Given this list of marker genes CPPED1, PPP1R14B, INPP5E, PPP1R14A, FAN1, PPP1R8, MGAT5, MTMR11, PABIR2, PPP4R3A, SH3RF2, TPTE2, PTPMT1, PLCB4, NANP, VRK3, DUSP8, PPP1R12A, DLG1, DUSP26, PTP4A3, G6PC3, NT5C1A, PTPN20, CDC14B, PPP3CB, ARL1, PLCD3, PDE3A, MYOZ1, CDCA2, RNGTT, DUSP22, PPP1R2C, PPP1R1B, PPP2R2B, PPP2R2C, MTMR3 (myotubularin related protein 3), YWHAE, MYH8, GNA12, PTP4A1, HSP90AB1, PGAM5, ALPL, PHOSPHO2, PTPN14, DUSP5, APTX (aprataxin), CASR, PON1, PLPP3, UBASH3B, PDXP, B3GAT3, ACP3, PPP1R36, PPM1M, APEX2, MINPP1, PPTC7, PPP1R10, SHOC2, PDE7B, PLCE1, PDE4C, INPP5D, PDE8B (phosphodiesterase 8B), CTDSP2, PHLPP1 (NCBI Gene Id 23239), TIGAR, DUSP2, PDE1A, PPP4R3C, PPP1R12C, PTP4A2, PLCXD2, PTPN22, EPHX2, PDE6B, HDDC2, CTDSPL, PLPP2, PHACTR2 (NCBI Gene Id 9749), DUSP23, DUSP7, MYH3, PHLPP2, PLCB1, INPP4A, PHACTR3, PTPRU, OCRL, INPP5J, DUSP13A, PPP1R3C (protein phosphatase 1 regulatory subunit 3C), PLPPR3, PDP2, PTPN1, PDE4B, NT5DC4, STYXL1, CTDNEP1, PPP1R35, SMPDL3B, PTPRN2, PTPRM, GDE1, CILP, PDE8A, CILP2, PPP2R5B, PTPRD, ILKAP, FRA10AC1, F2RL2, DUSP6, ACP6, TAB1, TIMM50, FBP1, NT5DC2, PPM1D, NT5C, PTPRS, CHRM5, MTMR6, HDHD2, DUSP15, PLCL1, PLCZ1, DUSP11, SSU72L3 (SSU72 like 3), SBF2, INPP5K, PPEF2 (NCBI Gene Id 5470), PPM1J, IMPA2, RCAN1, PPP1CB, SSH1, PPP6R3, TNS2, PLCD4, PPP1R9B, SSU72L4, DUSP12, CALM3, CABIN1, ACP7, SMPD3, NT5C3A, PLEK, SSU72, APEX1, PTPRN (protein tyrosine phosphatase receptor type N), CHRM1, PPP1R17, PHACTR1, PLPP5, ZEB2, PPP2R1A, PPP2CA, INPP5B (inositol polyphosphate-5-phosphatase B), ENPP7, ALPG, ALPI, SLC39A10, PDE11A, NT5DC3, CNEP1R1, PPP1R15B, MTMR10, PPP1R16B, INPP5F, SGPP1, SGPP2 (sphingosine-1-phosphate phosphatase 2), CDC14C, MPPED2, EYA1, PTPN4, NT5C3B, PABIR3, PPP2R3B, PLCH1, DUSP19, RCAN3, PIKFYVE, PPP2R1B (protein phosphatase 2 scaffold subunit Abeta), PTPN11, PTPRJ, LPIN3, PLD4, PTEN, ACP5, ACP1 (acid phosphatase 1), LGALS3, GDPD3, FAM83B, FRS2, PPP6C, PPP4R2, ACP2, GDPD1, PTPN21, PPP2R5D, MTM1, PPP2CB, GPCPD1, PPM1H, STX4, CD33 (NCBI Gene Id 945), PPP1R2P1, PFKFB3, CCL5, PPP1R16A, MTMR7, PPM1L, SNCA (synuclein alpha), ATP1A1, PPP1CC, PPP1R3B, PPM1A, PTPRK, ENPP6, PTPN7, PDE9A, PPM1K, PPP1R2B, PPP1R1A, PPM1G, SET, EPM2A, PTPN5, PLPPR1, DUSP10, PTN, PPME1, PRUNE1, PPP2R5E, PPP1R12B, TPRN, BOD1, PLCB2, SAMHD1, SSU72L1 (NCBI Gene Id 390033), SYNJ2, ENPP3, CHRM3, PPM1N, CA3, PLCH2, GPLD1 (NCBI Gene Id 2822), PTPRH, PLCD1, EYA4, SMPD4, PFKFB2, CDC25C, CTDSPL2, PPM1F, PPP4R1, SSU72L5, CAMK2G, MTMR2, PLCG2, PPP4R3B, PANK4, EDNRA, PPP1R2 (protein phosphatase 1 regulatory inhibitor subunit 2), PTPN9, ARMT1, PDGFRA, UBLCP1, PPP3R2, NT5E, AMBRA1, BMP2, PDE4D, PPP1R3E, SSU72L6 (SSU72 like 6), PPP3CC, PDE1C, G6PC2, PTPN13, PLD2, CNP, INPP4B, SYNJ1, PIP4P1, LCK, DUSP16, PPP6R2, PPP2R3A, PLPP6, LHPP, STYXL2, EYA2, CTNND1, YWHAB, ELFN1, PLPPR2, PTPRG, IGFBP3, PPP2R5A, THNSL2, DUSP9, ENSA (NCBI Gene Id 51620), PPP1R3D, ANKLE2, PLD6, PHOSPHO1, DUSP18, ITGA1, PXYLP1, CDKN3, PPEF1, PFKFB1, ATP1A2, SMPD2, PDE1B, PDE2A, PGP, PTPN6, PTPA, PPP1R15A (NCBI Gene Id 23645), PP2D1, SACM1L, PPP4C, PTPN18, ENPP1, PPP2R2A, DUSP13B, NT5M, PPP1R7, PDE3B, BCKDK, NAPEPLD, GDPD2, PPP5C, PTPRR, PLCL2, PIP4P2, MTMR14, SSH2, TPTE (transmembrane phosphatase with tensin homology), BDKRB2, PPA2, NOCT, TIPRL, PPP6R1, INPP1, RPAP2, BPNT1, TESC, NT5DC1, CCR5 (C-C motif chemokine receptor 5), DMPK, PPP1R11, SSH3 (NCBI Gene Id 82340), DUSP28, PFKFB4, PLPP1, PTPN3, ENOPH1, ANP32E, HTT, PTPDC1, SSU72L2, CDC25A, PPP3R1, TNS3, PDE5A, DUSP29, SBF1, PLPPR5, PUDP (pseudouridine 5'-phosphatase), CTDP1, LPIN1, PNKP, PTPN23, SIRPA, ACP4, HDDC3, PLPP4, DUSP14, PLD1 (NCBI Gene Id 5337), DUSP4, PTPRB, MYH6, PABIR1, PPP2R2D, PTPRO (protein tyrosine phosphatase receptor type O), URI1, PDE6G, PHPT1, PDIA3, PPP3CA, PPM1B, PALD1, TDP1, PTPRT, PSPH, NOTUM, G6PC1, PTPN2, IGBP1, PTPRQ, MTMR1, CCR1, ARF4, CDC25B, ENPP2, PDE6A, PPP1R1C, ARPP19, FBP2, HACD2, PLCXD3, PPP1R37, FIG4, PDE6H, MTMR8, BMP2K, LPIN2, INPP5A, LMTK2, PDE6C, NT5C2, GTF2F1, CALM2, PON3, NT5C1B, PPP1R26, IGFBP2, MPPE1, PLD3, PTK2, PDE4A, PLCB3, PLPP7, PHACTR4, PLCG1, HRAS, EIF2AK2, CRY2, PLCXD1, PPP1R14D, RCAN2, SAG (S-antigen visual arrestin), DUSP1, EYA3, PTPN12, PPM1E, PTPRZ1, PPP2R5C, DNAJC6, PTPRF, TNS1, TDP2, PLPPR4, PDE7A, DUSP21, ELFN2, GDPD4, CIP2A, VCAN, MTMR12, CTDSP1, CDC14A, PPP4R4, STYX, PPP1R14C, DUSP3, PPP1R27, ADPRM, PDGFRB, IMPA1, CALM1, PTPRC (NCBI Gene Id 5788), PDP1, PDE10A, FICD, HSP90B1, MTMR4, GDPD5, INPPL1, SMPDL3A, BPNT2, MDP1 (magnesium dependent phosphatase 1), SMPD1, ALPP, PPP1CA, PTPRE, PTPRA, here is a description of the gene set: Catalysis of the reaction: RPO-R' + H2O = RPOOH + R'H. This reaction is the hydrolysis of any phosphoric ester bond, any ester formed from orthophosphoric acid, O=P(OH)3. species: Homo sapiens Human Gene Set: GOMF_PHOSPHORIC_ESTER_HYDROLASE_ACTIVITY